Given this list of marker genes Ntpcr, Entpd1, Entpd7, D1Pas1, Abce1, Entpd4b, Ddx3x, Entpd4, here is a description of the gene set: Mouse Gene Set: GOMF_CTPASE_ACTIVITY species: Mus musculus Catalysis of the reaction: CTP + H2O = CDP + H+ + phosphate. May or may not be coupled to another reaction.